The following is a description of a gene set: part of: SLC transporter disorders The solute carrier family 12 member 1 (SLC12A1, NKCC2) is a kidney-specific, membrane-bound protein that cotransports two Cl- ions electroneutrally into cells with a Na+ ion and a K+ ion and plays a vital role in the regulation of ionic balance and cell volume. Defects in SLC12A1 can cause Bartter’s syndrome (BS1; MIM:601678), an autosomal-recessive disease salt-wasting disorder characterised by renal tubular hypokalaemia, metabolic alkalosis and hypercalciuria. Clinical features present in infancy and include muscle weakness, anorexia, polydipsia, polyuria, failure to thrive and mental and growth retardation. species: Homo sapiens Reactome Pathway: Defective SLC12A1 causes Bartter syndrome 1 (BS1), and this is the list of marker genes: SLC12A1